Given this list of marker genes Cish, Basp1, Trpv2, Rnasel, Cmtm6, Cxcl3, Rhoh, Ptpn1, Il1r2, Fcgr2b, Srgn, Wfdc21, Lilrb4b, Tarm1, Ccl6, Cxcr2, Id1, Fcgr3, Tes, Cd177, Cd164, Wfdc17, Lrg1, Ccr1, Fth1, Xbp1, Ifitm6, Mbd2, Ier3, Thbs1, Cd300lf, Cd47, Cd14, Cd33, Rab44, Ffar2, Slfn4, Plaur, Glipr2, Lcn2, Cd53, Nampt, Cxcl2, here is a description of the gene set: from publication Cui A, Huang T, Li S, Ma A, Pérez JL, Sander C, Keskin DB, Wu CJ, Fraenkel E, Hacohen N (PMID 38057668) Mouse Gene Set: CUI_NEUTROPHIL_IL1A_RESPONSE_UP Cytokines mediate cell-cell communication in the immune system and represent important therapeutic targets. A myriad of studies have highlighted their central role in immune function, yet we lack a global view of the cellular responses of each immune cell type to each cytokine. To address this gap, the authors created the Immune Dictionary, a compendium of single-cell transcriptomic profiles of more than 17 immune cell types in response to each of 86 cytokines (>1,400 cytokine-cell type combinations) in mouse lymph nodes in vivo. A cytokine-centric view of the dictionary revealed that most cytokines induce highly cell-type-specific responses. For example, the inflammatory cytokine interleukin-1β induces distinct gene programmes in almost every cell type. A cell-type-centric view of the dictionary identified more than 66 cytokine-driven cellular polarization states across immune cell types, including previously uncharacterized states such as an interleukin-18-induced polyfunctional natural killer cell state. Genes positively differentially expressed in cell type: Neutrophil upon treatment with cytokine: IL-1α in mouse lymph nodes in vivo. species: Mus musculus